Given this list of marker genes PRKAR2A, PRKAR1A, PKIA, PRKAR1B, NPY2R, PRKAR2B, PDE3A, LPAR1, here is a description of the gene set: studied in species Homo sapiens Any process that stops, prevents or reduces the frequency, rate or extent of cAMP/PKA signal transduction. Human Gene Set: GOBP_NEGATIVE_REGULATION_OF_CAMP_PKA_SIGNAL_TRANSDUCTION